The following is a description of a gene set: from publication Fu W, Ergun A, Lu T, Hill JA, Haxhinasto S, Fassett MS, Gazit R, Adoro S, Glimcher L, Chan S, Kastner P, Rossi D, Collins JJ, Mathis D, Benoist C (PMID 22961053) Human Gene Set: GSE40277_EOS_AND_LEF1_TRANSDUCED_VS_GATA1_AND_SATB1_TRANSDUCED_CD4_TCELL_DN The transcription factor FoxP3 partakes dominantly in the specification and function of FoxP3+ CD4+ T regulatory cells (Tregs), but is neither strictly necessary nor sufficient to determine the characteristic Treg transcriptional signature. Computational network inference and experimental testing assessed the contribution of several other transcription factors (TFs). Enforced expression of Helios or Xbp1 elicited specific signatures, but Eos, Irf4, Satb1, Lef1 and Gata1 elicited exactly the same outcome, synergizing with FoxP3 to activate most of the Treg signature, including key TFs, and enhancing FoxP3 occupancy at its genomic targets. Conversely, the Treg signature was robust to inactivation of any single cofactor. A redundant genetic switch thus locks-in the Treg phenotype, a model which accounts for several aspects of Treg physiology, differentiation and stability. Genes down-regulated in CD4 T conv over-expressing: IKZF4 and LEF1 versus GATA1 and SATB1 versus GATA1 and SATB1. studied in species Homo sapiens, and this is the list of marker genes: ATP2A3, GPR171, HVCN1, ADD3, GPD2, PRMT5, WEE1, TACC2, IFI44, RBL1, TWNK, XKRX, SYNE2, GPATCH4, GGT5, RIPK3, SGMS1, CCDC102A, ALOX5AP, RPP40, MCM2, TSR1, UTP15, MTHFD1, DIPK1A, ENC1, MCTP2, TSPYL4, BIRC5, TMEM229B, GALNT7, ASF1B, DLEU7, TMEM164 (NCBI Gene Id 84187), SLC16A5, ITPR1, CAMK1D, NRGN, MAD2L1, GALNT2, VIPR1, CNGA1, P4HA2, RGMB, LRR1, FOCAD, BRCA1, SMC2, RIGI, HYOU1, WDR76, TMEM9B, DOC2A, C16orf54, SLC25A10, PAG1, MMS22L, MOB3B, SLBP, AMPD1, ZNHIT6, LRRC8A, MYO10 (myosin X), SLC39A11, EEIG1, POLE2, TP53I13, RAD51AP1, GSTT2, RNF26, RCC1L, SLCO3A1 (NCBI Gene Id 28232), ACTR6, EVI2A, DPY19L1, INTS2, GGT6, ZBTB8A, TMCC3, POU2AF1, DTL, DPH5, TUBA4A, AMIGO2 (NCBI Gene Id 347902), ITGB3, FAM78A, TBC1D16, SEMA4A, DDX31, MCM5, TOR1AIP2, MAN1C1, ENTPD5, NUP50, MSRA, CKS1B, CRTAM, TMEM209, CAMKK2, LAT, PTGFRN, MAN2A2, SNHG12, ZCCHC12, LGR6, TNFRSF14, NAB1, APPL2, HAUS4, CDC45, SLC39A6, ARL4C, SRSF3 (serine and arginine rich splicing factor 3), CDCA4, SHCBP1, ABTB3, DGLUCY, ACVRL1, MED22, CDH18, UBE2S, COIL, AMZ1, CDC7, MAML2, TGFBR3, ATM, LGALSL, CENPM, OXCT1, TSHZ1, METTL9, ITGB5, OAS2, STK4, GYPC, RCBTB2, CBX4, FRMD8, CA2, RBM19, EPHX4, ZFPM1, RALY, SYCE2, ATN1, EGF, AP1B1, CLIP1, PAOX, LMNB1 (lamin B1), DDX39A, G3BP2, WDR45B, UBXN11, TTC7B, LYN, B4GALT5, TAF5L, EVI2B, KCNMB4, HPCAL1, GPR19, RFLNB, TSPAN14, MPG, ARHGAP39 (NCBI Gene Id 80728), MAP2, ALS2CL, HEXA, SELENON (selenoprotein N), AFP, ARHGAP29, LAIR1, ACP3, UPB1, PDE3B, RASGRP2, TRUB1, SLC35C2, DENND2C, NOC3L, QPCT, MFSD6, F2R, GMFG, SETD6, SKA2, CDC6, PDLIM1, MAK16, POP1, IKZF1, ALYREF, RAB11FIP4, SCML4, EMID1, FXYD5, LIMS4